Given this list of marker genes Sult1a1, Sult2a8, Sult2a6, Sult2a7, Sult2b1 (sulfotransferase family, cytosolic, 2B, member 1), Sult2a4, Sult2a2, Sult2a1, Sult1e1, Sult2a5, Sult2a3, here is a description of the gene set: Catalysis of the reaction: 3'-phosphoadenosine 5'-phosphosulfate + a phenolic steroid = adenosine 3',5'-bisphosphate + steroid O-sulfate. Mouse Gene Set: GOMF_STEROID_SULFOTRANSFERASE_ACTIVITY studied in species Mus musculus